Given this list of marker genes TCF4, NUP133, RABGGTB, FAR1, GHRH, CYP19A1, CNN3, PCOLCE, TLR1, HYAL3, CAMKMT, TPD52, GAS8, SPIRE1, ITPR3, CDK5R1, PRSS50, TAL2, PKIB, HOXD10, PIP4P1, MYSM1, CACNA2D1, LRP6, PKNOX2, MGA, STIMATE, ZDHHC23, SVIP, CYP39A1, DCAF17, FGR, MFSD4B, MFSD14B, PPM1K, GHDC, CREBL2, ATOH8, ZFPM2, CMPK2, SLC6A16, ACKR3, TMEM86A, RPL36 (NCBI Gene Id 92364), KCNMB2, YPEL2, SF3B5, GPR137, ZBP1, PAK3, CD40, CDK8 (cyclin dependent kinase 8), ATG2A, TNRC6A, VWC2, PPCS, KRT2, CITED4, ST6GALNAC5, PIK3IP1, RBM24, KRTAP17-1, DAPP1 (NCBI Gene Id 27071), RNASE6 (ribonuclease A family member 6), HEG1, TSPAN14, TRIB1, SIM1, CYP3A4, NDRG1, ARL4A, DOCK10, DGKI, MYLK, ARFGEF1, KICS2, FABP12, ZC3H7A, SYT8, RGS9BP, VAMP1, DSTYK, FBXO16, DTX1 (deltex E3 ubiquitin ligase 1), AGL, RGS18, AVPR1A, UBXN7, RESP18, ZMAT1, HERC1, MEX3A, RYR3, KDM5A, BAZ2B, TUSC2, CLOCK, ATP6V0A1, AJM1, PROKR2, ZBED6, UROS, HOPX, TLR3, RLF, PLCG1, WIF1, FZD4, NFKB2, HDAC9, MCFD2, PDE10A, GIP, SDHAF1, STAC2, NUS1, TAFA5, ADGRF5, SELENOW, BRWD1, VIL1, MGAT4A, ZNF638, OTOR, TLE1 (TLE family member 1, transcriptional corepressor), SNHG12, C9orf72, CPLX4, CELF5, TCEA2, AVL9 (AVL9 cell migration associated), C4orf33, XK, JMY, PLA2G6, COX7B2, IL5RA, CHST15, GLMN, ARMC3, CHD9, POMT1, PPARGC1A, PHLDB1, ADRA2B (NCBI Gene Id 151, adrenoceptor alpha 2B), LINGO1, DCUN1D1, TEX29, IGSF23, IST1, LHPP, NLRP14, PDE7A, FAT3, GNS, ARL15, STON1, NRROS (negative regulator of reactive oxygen species), C19orf73, SLAIN2, OIT3, CAB39L, BTG4, AKAP6, DOCK6 (dedicator of cytokinesis 6), TREML1, ATP6V1H, LMX1B, CELF3, IGFBP3, MCTP1, CYP2D6, TMOD4, SNX29, GPR35, CWF19L1, GCH1, CES5A, AKNAD1, CARMIL1, LLCFC1, KY, GJA3, CFAP251, TLX1, MEIOB, EDARADD (NCBI Gene Id 128178), THADA, RNF44, RIMOC1, HSD17B7, FAM43A, SERPINE2, IFT56, RPE65, DNAI4, ELN, NXPH3, DMRT3, here is a description of the gene set: Genes up-regulated in comparison of follicular B cells versus late germinal center (GC) B cells. from publication Wilke G, Steinhauser G, Grün J, Berek C (PMID 20518031) Upon immunization with a T cell dependent antigen naive follicular B cells (Fo) are activated and a germinal center reaction is induced. Within the next 2 weeks large germinal centers develop where the process of affinity maturation takes place. To analyze the gene expression profile of resting and activated B cells, follicular B cells (Fo), B cells from early (GC1) and late germinal centers (GC2) were isolated and their gene expression profile compared. species: Homo sapiens Human Gene Set: GSE28237_FOLLICULAR_VS_LATE_GC_BCELL_UP